Given this list of marker genes Gpr137, 1700012B07Rik, Gfpt1, Samhd1, Car7, Camta1, Slc22a23, Slc2a1, Ric3, Creb3l1 (NCBI Gene Id 26427), Ttbk2, Hrh4, Fgf7, Nufip2, Grk5, Ap1g1, Dnajb13, Pax9, Tcf12, Dock3, Tanc2, Tmem132c, Frmd7, Tmpo, Prxl2c, Slc9a7, Heph, Rbm39, Ano5, Hmgb2, Nucb2, Dlg2, Pcbp2, Tcte2, Erv3, Cyp2c38, Zfp74, here is a description of the gene set: Genes predicted to be targets of miRBase v22 microRNA mmu_miR_702_5p in miRDB v6.0 with MirTarget v4 prediction scores > 80 (high confidence targets). from publication Chen Y, Wang X (PMID 31504780) Mouse Gene Set: MIR_702_5P species: Mus musculus